The following is a description of a gene set: species: Mus musculus Any process that modulates the frequency, rate or extent of calcium-mediated signaling, the process in which a cell uses calcium ions to convert an extracellular signal into a response. Mouse Gene Set: GOBP_REGULATION_OF_CALCIUM_MEDIATED_SIGNALING, and this is the list of marker genes: Ada, Sppl3, Gsk3b, Homer2, Cmklr1, Actn3, Htr2c, Nfat5, Cd24a, Drd4, Atp2b4, Cd8a, Grm5, Slc9a1, Calcr, 3425401B19Rik, Pcp4, Pdgfrb, Efhb, Mir1a-2, Ppp3ca, Fcer1a, Homer3, Akap5, Rcan1, Ppp3r1, Trat1, Nron, Nmur1, Ptprc, Cdh13, App, Erbb3, Ppp3r2, Prnp, Mir1a-1, Camta1, Clec7a, Siglecg, Slc8a2, Ptbp1, Ptprj, Mapk7, Jpt2, Zap70, Akap6, Exoc4, Myoz2, Cmya5, Fhl2, Nrg1, Adora3, Sla2, Cd4, Calm2, Car8, L1cam, Pdk2, P2rx4, Mapt, Cd22, Tnf, Ncam1, Kdr, Chp2 (calcineurin-like EF hand protein 2), Ramp3, Tmem100, Dyrk2, Itgal, Ppp3cc, Chp1, Gpr62, Itpr1, Cib1, Bst1, Igf1, Lhcgr, Cherp, Mtor, Iapp, Myoz1, Edn1, Lrrk2, Htt, Ccl3, Slc24a4, Sco1, Rgn, Pdgfra, Myh7b, Hint1, Edn2, Egln1, Tbc1d10c, Ppp3cb, Neurod2, Tmbim4, Lmcd1, Rit2, Fkbp1b, Ncs1, Trem2 (NCBI Gene Id 83433), Tmbim1, Negr1, Cd3e, Plcg2, Selenok, Syk